Given this list of marker genes IL1B, SSH1, TAF1, PDXP, P2RX6, PANX1, ENPP1, CIB2, KCNJ11, ABCC9, RYR3, HSP90B1, P2RX7, P2RX5, KCNJ8, NT5E, ASPH, PKLR, P2RY12, P2RX4, TRPM4, SOD1, P2RY2, P2RY11, DNTT, P2RX1, P2RX2, P2RY1, TOP2B, P2RX3 (NCBI Gene Id 5024), TRPC3, TRPV1, P2RY4, here is a description of the gene set: Any process that results in a change in state or activity of a cell or an organism (in terms of movement, secretion, enzyme production, gene expression, etc.) as a result of an ATP (adenosine 5'-triphosphate) stimulus. studied in species Homo sapiens Human Gene Set: GOBP_RESPONSE_TO_ATP